The following is a description of a gene set: part of: Virus Assembly and Release Reactome Pathway: Assembly of Viral Components at the Budding Site Following synthesis on membrane-bound ribosomes, the three viral integral membrane proteins, HA (hemagglutinin), NA (neuraminidase) and M2 (ion channel) enter the host endoplasmic reticulum (ER) where all three are folded and HA and NA are glycosylated. Subsequently HA is assembled into a trimer. HA, NA and M2 are transported to the Golgi apparatus where cysteine residues on HA and M2 are palmitoylated. Furin cleaves HA into HA1 and HA2 subunits and all three proteins are directed to the virus assembly site on the apical plasma membrane via apical sorting signals. The signals for HA and NA reside on the transmembrane domains (TMD) while the sorting signal for M2 is not yet characterized. The TMDs of HA and NA also contain the signals for lipid raft association. Lipid rafts are non-ionic detergent-resistant lipid microdomains within the plasma membrane that are rich in sphingolipids and cholesterol. Examination of purified virus particles indicates that influenza virus buds preferentially from these microdomains. studied in species Homo sapiens, and this is the list of marker genes: CANX, NA, HA, CALR, NP, M